Given this list of marker genes JADE1, SLC2A10, ZDBF2, SLC25A26, KIAA0408, DGKH, DUSP18 (dual specificity phosphatase 18), TOM1L1, RNASE11, C11orf97, EFR3A, SRP19, PRDM1, PTPDC1, ADGRL2, DPYSL3, LRAT, ADGRG2, METAP2, ABHD10, SSH2, NAV1, ANKRD13C, MGP, AIMP1, B3GNT5 (NCBI Gene Id 84002), MCIDAS, HMGN1, RORA, EHF, OGG1, RIMS2, VPS13A, LACTB, ADGRF5, CNTLN, ONECUT2, CHSY1, ZMAT1, CEP128, PIP5K1A, FSD1L, EPB41L1, DEPDC4, TRIM44, CAMKK2, SESTD1, RBM27, PRICKLE2, F5, CHRM2, ACTN4, FXN, ADAM28, CSNK1G3, CD81, EEF1A1, DGAT2, HYAL4, RIT2, DPH3P1, ZNF700, KPNA6, CIC, FBXO32, YY2, ZNF287, CDKN2D, TIAM1, HECW1, ETS1, CDH11, CCDC172, STAM, FAM13C, DLC1, RPL36A-HNRNPH2, MS4A2, ZNF281 (NCBI Gene Id 23528), NIPBL, IL17RD, CLEC16A, CDK2, SEMA3C, AHSG, RFX7, RREB1, SFRP4, ADAMTS1, ZNF852, OGFRL1, SNAP23, UHMK1, ZHX2, GADD45A, TFAP2B, SORCS1, ZBTB41, KTN1, FA2H, RUNX2, UTP25, STEEP1, ZSWIM6, NAV3, TPT1, ANKLE2, TMEM138, LRRC8C, VCL, SNX19, CCDC34, GRIA1 (glutamate ionotropic receptor AMPA type subunit 1), CROT, ANKRD52, SV2B, NEGR1, ATP5IF1, UBA6, DTWD2, ACAN, EVA1C, NXPH1, ALG6, RBM47, SSBP3, MTCL3, BCL6B, here is a description of the gene set: studied in species Homo sapiens Human Gene Set: MIR1248 from publication Chen Y, Wang X (PMID 31504780) Genes predicted to be targets of miRBase v22 microRNA hsa-miR-1248 in miRDB v6.0 with MirTarget v4 prediction scores > 80 (high confidence targets).